The following is a description of a gene set: Genes up-regulated in megakaryo-erythrocyte progenitors versus pro-B lymphocytes. Human Gene Set: GSE15330_MEGAKARYOCYTE_ERYTHROID_PROGENITOR_VS_PRO_BCELL_UP Regulation of lineage potential and transcriptional priming by Ikaros. New insight is provided into a bivalent regulation of lineage priming in the HSC and its lympho-myeloid restricted progeny the LMPP by the lymphoid lineage-determining factor Ikaros Whereas Ikaros is responsible for the activation of a cascade of lymphoid expression programs and for the establishment of lymphoid potential from the HSC to the LMPP it is also responsible for the repression of stem cell and erythroid genetic programs that are incompatible with further lineage restrictions emanating from the LMPP from publication Ng SY, Yoshida T, Zhang J, Georgopoulos K (PMID 19345118) studied in species Homo sapiens, and this is the list of marker genes: CMTM3, CA5B, OLFM1, CCR1, SMAD4, TM9SF2, PNPO, ZFP36L2, ADORA2B, GPSM3, ANKH (NCBI Gene Id 7995), XYLB, DNMBP, MAPK3, NABP1, APLP2, KLF13, MARVELD1 (MARVEL domain containing 1), SLC17A9, NEK6, VPS4B, CUX1, IQGAP1, SLC4A8, CERK, ASPH, CYB5A, DERL1, AP3D1, CRK, SIAH1, IFNGR1, RB1, CAMK4, DCBLD2 (NCBI Gene Id 131566), FBXO15, LRRC8A, HCLS1, EID1, POR, ABHD17A, TOPORS, RAP1B, TXNDC17, UBAC2, PRR13, CCDC88C, PLEKHA1, TNFRSF25, LONP2, CDK5RAP3, CSRP2, B3GNT2, SLC9A1 (solute carrier family 9 member A1), KIF22, RPS14, N4BP3, THAP12, ATP6V0E1, USP22, CIP2A (NCBI Gene Id 57650), KPNA2, MGLL, SLF2, PPP1R18, FAM8A1, MAP1LC3B, PKIB, S1PR1, DCTN4, AHSG, SACS, PRR14, SNX12, TSPAN5, TMEM101, COX4I1, IER5, ATP6V0A1, TMEM41A, NUSAP1, ARL8A, CLTB, GLO1, UFM1, LAMTOR4, JADE1, SBK1, HIPK2, HASPIN, CYFIP2, PC, CTSV, ZNF451, SYN1, EIF6, UBE2B, CTNNA1, SH3BGRL3 (SH3 domain binding glutamate rich protein like 3), SMAD1, VEGFB, MNT, SPC25, SPA17, TRAPPC1, PTPRJ, UBTD1, IL7R (interleukin 7 receptor), MYOF, TAX1BP1, CAPN15, EFEMP2, FMNL1, CASKIN2, SLC25A45, HAO1, PKP3, RAB18 (RAB18, member RAS oncogene family), GABARAP, GSN, ZNF276, NLGN2, GNAT2, CREB3L2, TRAPPC10, CTTN, CD37, AURKB, FTH1 (ferritin heavy chain 1), CXCR6, HLX, KCTD12 (NCBI Gene Id 80710), UIMC1, ACTR1A, POLR2I, TOX4, TFG (NCBI Gene Id 50989), ADARB1, FTL, SUCLG1, GJA1, NTPCR, CDK9, ABHD15, IMPDH1, NAB1, CDCA3, ABCB6, INHA, RIBC2, KIFAP3, MRPL58, RPTN, SPRED1, SGPP1, GNG2, TMED3, MROH1, TSPO (translocator protein), ALG5, PACS1, TMEM14C, ALDH3A2, CDC42EP3, AFG2A, SMAP2, CCNF, RAB14, LRRC8C, SERPINE1, SLC15A2, MYBL2, CNIH1, CCR2, CDK5 (cyclin dependent kinase 5), FTCD, NAAA, PIMREG, ZC3H12C, CAMKK1, UBR3, RRAD, CA8, ST8SIA1, GMFG, KCTD20, ACSBG1, LAMP2, DIPK2A, SNAP47, SYNGR1, FBXO21, PHF7 (PHD finger protein 7, NCBI Gene Id 51533), COX7A2L, ARL4C, SEC14L1, CLIC1, BCAS3, CNTD1, SORD